The following is a description of a gene set: species: Mus musculus The process in which the left cardiac ventricle is generated and organized. Mouse Gene Set: GOBP_CARDIAC_LEFT_VENTRICLE_MORPHOGENESIS, and this is the list of marker genes: Tgfb2, Ahr, Hand1, Hey2, Klk1b1, Eva1a, Gsk3a, Ryr2, Fgf9, Tbx5, Pcdha9, Rnls, Cpe, Npy5r, Npy2r, Ednra, Sfrp2, Smad4, Rbpj, Foxf1, Naglu, Notch1, Tgfbr2